Given this list of marker genes ADTRP, RAB30, PCED1B, EPPK1, SHISAL2A, PLEKHA1, NOG, TAGAP, AK5, PASK, RPS4Y1, GIMAP8, C1orf162, VSIG1, GIMAP5, LDLRAP1, IL6R, ATP10A, INPP4B, UPP1, here is a description of the gene set: from publication Lee MS, Hanspers K, Barker CS, Korn AP, McCune JM (PMID 15210650) To develop a comprehensive catalogue of phenotypic and functional parameters of human CD4(+) T cell differentiation stages, we have performed microarray gene expression profiling on subpopulations of human thymocytes and circulating naive CD4(+) T cells, including CD3(-)CD4(+)CD8(-) intrathymic T progenitor cells, CD3(int)CD4(+)CD8(+) 'double positive' thymocytes, CD3(high)CD4(+)CD8(-) 'single positive' thymocytes, CD3(+)CD4(+)CD8(-) CD45RA(+)CD62L(+) naive T cells from cord blood and CD3(+)CD4(+)CD8(-) CD45RA(+)CD62L(+) naive T cells from adult blood. These subpopulations were sort-purified to >98% purity and their expressed RNAs were analyzed on Affymetrix Human Genome U133 arrays. Comparison of gene expression signals between these subpopulations and with early passage fetal thymic stromal cultures identify: (i) transcripts that are preferentially expressed in human CD4(+) T cell subpopulations and not in thymic stromal cells; (ii) major shifts in gene expression as progenitor T cells mature into progeny; (iii) preferential expression of transcripts at the progenitor cell stage with plausible relevance to the regulation of expansion and differentiation of these cells; and (iv) preferential expression of potential markers of recent thymic emigrants in naive-phenotype CD4(+) T cells from cord blood. Further evaluation of these findings may lead to a better definition of human thymopoiesis as well as to improved approaches to monitor and to augment the function of this important organ of T cell production. Human Gene Set: LEE_NAIVE_T_LYMPHOCYTE Genes enriched in the naive circulating T lymphocytes compared to the earlier differentiation stages. studied in species Homo sapiens